The following is a description of a gene set: studied in species Mus musculus Mouse Gene Set: chr14D3, and this is the list of marker genes: Gm4291, Htr2a, Gm10845, Gm9578, Gm18147, Gm4821, Cyp2c73-ps, Gm4285 (NCBI Gene Id 100043189), Gm26251, E130202H07Rik, Gm18683, Enox1, Gm10132, Pcdh8, Gm10847, Snora31, Gm7004, 2900040C04Rik, Gm19311, Gm16409, Gm30970, Gm23622, Lrch1, Gtf2f2, Esd, Pcdh17, Gm9198, Sugt1, Gm19120, Lcp1 (lymphocyte cytosolic protein 1), Akap11, Itm2b, Fam216b, Wbp4, Gm1587, 4930431P22Rik, Med4, Gm29800, Epsti1, Cbx3-ps6, Gm19301, Dnajc15, Gm30584, Gm18525, Cysltr2, Gm17923, Gm9212, Ccdc122, 4933402J15Rik, Tsc22d1, Rubcnl, Naa16, Sucla2, Olfm4, Dgkh, Gm18368, Cog3 (component of oligomeric golgi complex 3), Gm4632, Gm4266, Rcbtb2, Kctd4, Vwa8, Gm25517, Zfp957, Serp2 (NCBI Gene Id 72661), Mtrf1, Gm49174, Kbtbd7, Tnfsf11 (NCBI Gene Id 21943), Gm24774 (NCBI Gene Id 115485957), Gm15628, Lacc1, Rps2-ps6 (ribosomal protein S2, pseudogene 6), Rgcc, 1700108F19Rik, Slc25a30, Cby2, Gm4278 (predicted gene 4278), Fkbp1a-ps1, Lpar6, Mir687, Gm41219, 9630013A20Rik, Gm6997, Gm19050, Gm18605, Gpalpp1, Lrrc63, Gm6994, Kbtbd6, Gm30467, Gm6999, Cpb2, Rb1, Siah3, Tpt1, Nudt15, Cnmd, 4930452G13Rik, Gm6986, Nufip1, Mir1971, Mir759, Erich6b, Gm32455, Elf1, Gm19098, Zc3h13 (zinc finger CCCH type containing 13)